The following is a description of a gene set: electronically inferred by orthology from the curated human pathway part of: Transport of small molecules This event has been computationally inferred from an event that has been demonstrated in another species.<p>The inference is based on the homology mapping from PANTHER. Briefly, reactions for which all involved PhysicalEntities (in input, output and catalyst) have a mapped orthologue/paralogue (for complexes at least 75% of components must have a mapping) are inferred to the other species. Reactome Pathway: ABC-family protein mediated transport studied in species Mus musculus, and this is the list of marker genes: Abcb8, Abcb7, Abcb5, Abcc2, Derl1, Abcg8, Psmb7, Psmb5, Psmc2, Psma6, Vcp, Abcc3, Psmc5, Rps27a, Pex19, Eif2s3x, Abca12, Psma4, Abcc10, Abcd2, Psmb6, Psma7, Psma2, Derl3, Psmd13, Ubb, Abca9, Psmc6, Psmd7, Abcb9, Psmd6, Psmc3, Abcg5, Erlec1, Abcc4, Kcnj11, Psmd12, Psma1, Abca7, Abcg1, Abca5, Psmc1, Abca8b, Apoa1, Psmd1, Abcd1 (NCBI Gene Id 11666), Psma5 (NCBI Gene Id 26442), Psmc4, Sel1l, Psma3, Abcb4, Psmb4, Abcb6, Abca6